Given this list of marker genes SLC37A4, AQP9, ALB, GABRB3, TTR, KCNJ3, GJB1, SLC16A2, SLC6A1, GABRP, P2RX1, SLC9A5, SLC10A1, here is a description of the gene set: Human Gene Set: MODULE_415 species: Homo sapiens Genes in the cancer module 415.